The following is a description of a gene set: Binding to single-stranded DNA. Mouse Gene Set: GOMF_SINGLE_STRANDED_DNA_BINDING species: Mus musculus, and this is the list of marker genes: Ybx3, Rad54l, Purb, Lrpprc, Bivm (NCBI Gene Id 98474), Ddx11 (DEAD/H box helicase 11), Alyref2 (Aly/REF export factor 2), Polr2g, Hmgb1, Zranb3, Blm, Hnrnpu, Nme1, Pot1a, Pcbp3, Smc4, Tsn, Smarcal1, Pms2, Ercc4, Terf2, Pcbp2, Pot1b, Rad52, Hsf1, Ssbp1, Mlh1, Rad50, Mcm2, Radx, Cdc45 (NCBI Gene Id 12544), Fubp3, Ten1, Ssbp2, Pcbp1, Twnk, Stn1 (NCBI Gene Id 69648), Rad51, Pola1, Top3a, Smc6, Rad51ap1, Mms22l, Terf2ip, Rad51d, Swsap1, Nabp1, Ssbp3, Dmc1, Msh3, Trp53, Sub1, Mcm5, Mcm3, Mcm10, Smug1, Anxa1, Ercc1, Wdr48, Ighmbp2, Hnrnpa2b1, Hmces, Tsnax, Nucks1, Rpa2, Neil3, Dhx9, Rpa3, Mcm9, Fam111a, Ncl, Rtf1, Mcm4 (minichromosome maintenance complex component 4), Brca2, Alyref, Meiob, Top1, Mcm6, Shoc1, Setmar, Msh2, Smarca1, Pura, Samhd1, Nabp2, Rexo4, Fbh1, Tdp1, Jchain, Pou4f1, Rad51b, Ctc1 (CTS telomere maintenance complex component 1), Ighm, Tdp2, Xpc, Rpa1, Hnrnpdl, Mcm7, Hrob, Cnbp, Hnrnpk, Lonp1, Terf1, Sprtn, Rnf138, Spen, Rad18 (NCBI Gene Id 80614), Hnrnpa1, Mcm8, Nol12, Cry2, Trex1, Ybx1, Ercc5, Ptbp1, Smc5, Recql (NCBI Gene Id 19691), Polr2h, Rnf138rt1, Aptx, Polr3c, Smc2, Dhx36